Given this list of marker genes MRPS11, PSMB3, SNRNP25, KCNAB2, DHRS1 (dehydrogenase/reductase 1), ERMP1, MIR592, NPR3, MVB12A, PABPC1, NUP37, DSCAM, RAB33A, RFC2, PRDX4, MRPL27, THSD7A, CASP3, CELSR1, CLIC6, PIGQ, MRPS14, VWA5B2, IFT122, MVD, ELOVL1, EDC4, YRDC, LANCL2, PSMB8, NICN1, STARD3NL, EIF3M, CEACAM20, THAP11, DGKI, SERINC3, TONSL, ATP5IF1, HIGD2A, SP8, SINHCAF, TWF2, PSMA5, ZFPM2, PSMB6, PDE12, BLVRA, XAF1, PAQR7, FIGN, MYO5B, COPS9 (NCBI Gene Id 150678), RNASEH2A, CPXM2, LYAR, NOL12, FBXO16, RHOA, MRPS18B, GSTK1, AMPH, GRK3, GAR1, OVOL3, GCLM, COQ7, C2orf49, RNF187, FBXO17 (F-box protein 17), EGFLAM, DNAJA2, UQCC3, CTNNAL1, GPATCH4, COMMD3, PSMA7, COL8A2, SRPK1, WDR4, SPCS1, IRF4 (NCBI Gene Id 4592), SIPA1L1, TIPIN, PHGDH, NFE2L2, RNASEK, SMIM11, ATP6V1C2, PBLD, IL17A, ADAMTSL1, CCDC124, AOC1, CLDN11, RPL13, WRNIP1, CES4A, CNBP, TIFA, SNX16, RPS27L, GNL3L, APC2, SLC25A5, KCNN2, ELOC, MRPL36, NFU1 (NFU1 iron-sulfur cluster scaffold), ATP5MC1, GXYLT2 (glucoside xylosyltransferase 2), PILRA, SDR16C6P, ABCA5, ADIPOR1, FOSL2, PLK2, MIR188, BEX3, ALDH2, COX20, AIFM1, TRAIP, BLMH, MIR302B, PTH2, PPP4C, ELOF1 (NCBI Gene Id 84337), ATP5MC2, DIP2C, ETV4, CLEC10A, TPSB2 (tryptase beta 2), PARP16, MFSD5, CFHR1, UQCR11, FAT1, OSGEP, SLC19A1, SCN3B (sodium voltage-gated channel beta subunit 3), APP, PRPF31, GSS, KRT7, POMP, WNT10B, MAVS, AIP, LRRC75A, ESD, IFT22, MED30, HSD17B7, GJB5, BPNT1, HDAC4, CCDC9, FIS1, here is a description of the gene set: studied in species Homo sapiens from publication Olex AL, Hiltbold EM, Leng X, Fetrow JS (PMID 20682054) BACKGROUND: Dendritic cells (DC) play a central role in primary immune responses and become potent stimulators of the adaptive immune response after undergoing the critical process of maturation. Understanding the dynamics of DC maturation would provide key insights into this important process. Time course microarray experiments can provide unique insights into DC maturation dynamics. Replicate experiments are necessary to address the issues of experimental and biological variability. Statistical methods and averaging are often used to identify significant signals. Here a novel strategy for filtering of replicate time course microarray data, which identifies consistent signals between the replicates, is presented and applied to a DC time course microarray experiment. RESULTS: The temporal dynamics of DC maturation were studied by stimulating DC with poly(I:C) and following gene expression at 5 time points from 1 to 24 hours. The novel filtering strategy uses standard statistical and fold change techniques, along with the consistency of replicate temporal profiles, to identify those differentially expressed genes that were consistent in two biological replicate experiments. To address the issue of cluster reproducibility a consensus clustering method, which identifies clusters of genes whose expression varies consistently between replicates, was also developed and applied. Analysis of the resulting clusters revealed many known and novel characteristics of DC maturation, such as the up-regulation of specific immune response pathways. Intriguingly, more genes were down-regulated than up-regulated. Results identify a more comprehensive program of down-regulation, including many genes involved in protein synthesis, metabolism, and housekeeping needed for maintenance of cellular integrity and metabolism. CONCLUSIONS: The new filtering strategy emphasizes the importance of consistent and reproducible results when analyzing microarray data and utilizes consistency between replicate experiments as a criterion in both feature selection and clustering, without averaging or otherwise combining replicate data. Observation of a significant down-regulation program during DC maturation indicates that DC are preparing for cell death and provides a path to better understand the process. This new filtering strategy can be adapted for use in analyzing other large-scale time course data sets with replicates. Genes down-regulated in bone marrow-derived dendritic cellstreated by poly(IC): 0h versus 24h. Human Gene Set: GSE21033_CTRL_VS_POLYIC_STIM_DC_24H_DN